Given this list of marker genes INS, PCSK2, PCSK1, GCG, GLP1R, SLC2A1, here is a description of the gene set: GLP-1 from intestine and pancreas and role in glucose homeostasis species: Homo sapiens Human Gene Set: WP_GLP1_FROM_INTESTINE_AND_PANCREAS_AND_ROLE_IN_GLUCOSE_HOMEOSTASIS